The following is a description of a gene set: Genes predicted to be targets of miRBase v22 microRNA mmu_miR_463_5p in miRDB v6.0 with MirTarget v4 prediction scores > 80 (high confidence targets). from publication Chen Y, Wang X (PMID 31504780) species: Mus musculus Mouse Gene Set: MIR_463_5P, and this is the list of marker genes: Cpox, Satb2 (special AT-rich sequence binding protein 2), Aoah, Trpc5os, Xpo7, Gjc3, Otud1, Gse1, Cpsf6, Zmym2, Rufy3, Tnfrsf21, Uevld, Xrn2, Cdkn2aip, Ptp4a1, Ppig, Grk1, Spin4, Zfp664, Pfn2, Slc18b1, H2bc21, 2610028H24Rik, Myb, Epyc, Ap1s3, Prelid3b, Egln1, Tenm3, Kdm1b, Lemd3, Ap3m1, Rtf2, Tfap2b, Prps1, Hivep2, Zfp488, Lrrc8c, Fsd1l, Paip1, Stk26, Ncam2, Sall1, Hs6st2, Colgalt1, Veph1 (ventricular zone expressed PH domain-containing 1), Ebag9, Rai14, Auh, Zfp953, Ammecr1, Luc7l2, Khdrbs1, Cdo1, Pla2r1, Apc, Fmo2, Zfp251, Mex3a, Tyms, Grm3, Dnm1l (dynamin 1-like), Ccnl2, Nsun4, Caap1, Zfp1009, Nr2e1, Slc7a2, Tcf12, Acad8